Given this list of marker genes PAX2, ASXL1 (NCBI Gene Id 23393), AGTR2, HNF1B (HNF1 homeobox B), HNF1A, LRRK2, here is a description of the gene set: Human Gene Set: GOBP_REGULATION_OF_KIDNEY_SIZE species: Homo sapiens Any process that modulates the size of a kidney.